The following is a description of a gene set: A process in which a protein is transported to, or maintained in, a location within the mitochondrion. studied in species Homo sapiens Human Gene Set: GOBP_PROTEIN_LOCALIZATION_TO_MITOCHONDRION, and this is the list of marker genes: DNLZ, TOMM22, TIMM17B, SIRT4, ADCY10, AIP, PAM16 (presequence translocase associated motor 16, NCBI Gene Id 51025), TOMM70, UBE2D3, PRKN, MARCHF5, MICALL2, MTCH1, BBC3, MTX2, DNAJC15, HSPA4, NMT1, HK2, RALA, HSPD1, TMEM126A, TOMM34, CSNK2A2, TIMM29, LRRK2, PARL, RNF31, DNAJC19, SH3GLB1, ISG15, MFN2 (mitofusin 2), BCS1L, BID, BAP1, TSPO, NDUFA13, MAVS, MIPEP, TOMM5, TOMM40L, TIMM10B, AP3B1, MOAP1, TIMM13, EIF2AK1, FZD5, CHCHD4, DNM1L, ATG13, TIMM8B, HAX1, LEPROT, IMMP2L, SAMM50, HPS4, AKT1, MAPK8, CDKN2A (cyclin dependent kinase inhibitor 2A), AGK, UBE2L3, GZMB (granzyme B), BAG3, LMAN1, MTERF4, BAX, PINK1, TOMM6, TOMM20, BAG4, TIMM23, RNF186, MTX1, PMPCA (NCBI Gene Id 23203), MTCH2, RAC2, TIMM23B, HSPA1L, HUWE1, AIFM1, TRMT10B, TOMM40, TIMM50, SARM1, MAPT, PRKAA1 (NCBI Gene Id 5562), GDAP1, TIMM17A, IMMP1L, CALM3, TIMM9, TIMM8A, PIN1, MFF, ABLIM3, BNIP3L, BCAP31, COX18, NPEPPS, DNAJA1, FIS1, VPS11, SREBF1, UBL4B, TOMM20L (NCBI Gene Id 387990), MAIP1, OXA1L, SAE1, GSK3A, HK1, TOMM7, GFER, DDIT3 (DNA damage inducible transcript 3), GRPEL1, RHOU, TIMM21, ATP5IF1, SREBF2, PITRM1, HTRA2, TIMM22, C11orf65, PMPCB, FKBP8, FBXO7, ROMO1 (reactive oxygen species modulator 1), HSP90AA1, MGARP, TIMM44, ARIH2, GRPEL2, FBXW7, UBE2J2, SIAH3, UBL5, USP36, TIMM10